Given this list of marker genes MYD88, MIR146A, DEFB124, MAP2K5, F2RL1, MCOLN2, TLR4, POSTN, HMGB1, KLF4, OAS3, FOXP1, LPL, MBP, OAS1, TNF, MIF, TGFB1, CD74, MIR766, TIRAP, here is a description of the gene set: Human Gene Set: GOBP_CHEMOKINE_C_X_C_MOTIF_LIGAND_2_PRODUCTION studied in species Homo sapiens The appearance of chemokine (C-X-C motif) ligand 2 due to biosynthesis or secretion following a cellular stimulus, resulting in an increase in its intracellular or extracellular levels.